The following is a description of a gene set: Mouse Gene Set: WP_CHEMOKINE_SIGNALING_PATHWAY Chemokine signaling pathway studied in species Mus musculus, and this is the list of marker genes: Ikbkg (NCBI Gene Id 76324, inhibitor of kappaB kinase gamma), Shc3, Adcy1, Ccr7, Ccl19, Gngt2, Grk6, Vav3, Stat2, Ccr1, Shc1, Gng4, Cdc42, Prex1, Cxcr1, Tiam2, Hras, Stat3, Crkl, Ccl27al, Ccl2, Ccr6, Rela, Akt2, Gng12, Ccl3, Grk5, Prkcz (protein kinase C, zeta), Ccl11, Ccl7, Jak2, Gnb4, Ccl26, Prkacb, Jak3, Ccl27a, Nfkbib (NCBI Gene Id 18036), Ccr5, Adcy8, Cxcr4, Cx3cr1, Arrb1, Cxcr5, Cx3cl1, Cxcr2, Ccr10, Xcr1, Rac1, Ccr2, Prkcd, Akt3, Ppbp, Gnb3, Gsk3a, Gng14, Braf, Ikbkb, Stat1, Chuk, Pik3r3, Pik3cg, Rock2, Pik3r2 (phosphoinositide-3-kinase regulatory subunit 2), Pik3ca, Rock1, Ccl27b, Prkcb, Ccl21a, Gnai1, Gng8, Ccr8, Gng2 (guanine nucleotide binding protein (G protein), gamma 2), Fgr, Wasl, Plcb4, Ccr4, Adcy5, Cxcl16, Rhoa, Gngt1, Nfkb1, Plcb1, Nras, Prkx, Sos1, Foxo3, Rap1b, Stat5b, Sos2, Bcar1 (NCBI Gene Id 12927), Pik3r5, Shc2, Gng13, Grk4, Ccr1l1, Gsk3b, Pik3cb, Cxcl12, Shc4, Hck, Adcy4, Cxcl9, Adcy2, Grk2, Cxcl15, Ccl25, Gng11, Pik3r1, Ptk2, Cxcl1, Itk, Pak1, Cxcl5, Ccl5, Ccr3, Rasgrp2, Gng5, Cxcl2, Pf4, Tiam1, Gng3, Adcy3, Ccl24, Ccl1, Pxn, Cxcl14, Lyn, Crk, Mapk1, Was, Ccl17, Adcy9, Raf1, Grb2, Prkaca, Elmo1, Dock2, Ccl9, Ccl12, Ncf1, Pard3, Plcb3, Gnb1, Nfkbia, Ccl28, Cxcl10, Gng10, Cxcl13, Adcy7, Gng7, Csk, Kras, Vav1, Gnb5, Pik3cd, Plcb2, Gnai2, Rap1a, Mapk3, Map2k1, Ccl4, Akt1, Rac2, Gnai3, Cxcr3, Ccl20, Arrb2, Ccl6, Grk1, Xcl1, Cxcr6, Adcy6, Ccr9, Ptk2b (NCBI Gene Id 211703), Vav2 (vav 2 oncogene), Ccl8